The following is a description of a gene set: from publication Schaefer CF, Anthony K, Krupa S, Buchoff J, Day M, Hannay T, Buetow KH (PMID 18832364) Human Gene Set: PID_AMB2_NEUTROPHILS_PATHWAY amb2 Integrin signaling species: Homo sapiens, and this is the list of marker genes: PLAT, PLG, MST1, AKT1, NFKB1, BLK, LRP1, RHOA, CCN2, SELPLG, LPA, IL6, ROCK1, SELP, RAP1A, APOB, ITGAM, JAM2, YES1, LYN, MST1R, MYH2, HMGB1, AGER, JAM3, FGR, RAP1B, ITGB2, FYN (FYN proto-oncogene, Src family tyrosine kinase), TNF, PRKCZ, PLAUR, SRC, PLAU, MMP9, THY1 (Thy-1 cell surface antigen), ICAM1, LCK, MMP2, TLN1, HCK